Given this list of marker genes CEP128, AFF3, UPB1, SUFU, HSPA1B, LIG4, TPD52, TMED1, MAD2L1, GADD45B, ELOF1, LY6E, EIF4EBP1, DALRD3, TUBE1, MTMR14, PRCP, SPC24, DBNL, TFRC, MGAT1, FCHSD2, L1CAM, SH3GLB1, SLC66A1, TNS3, RAB39A, CFAP20DC, NCOA1, HLA-C, KDM2B, GALNT4, HTR4, PPP4R1, HDAC5, DAPP1, PIP4P1, ZBTB7A, BHLHE40, BCKDHA, ZNF326, HS6ST1 (heparan sulfate 6-O-sulfotransferase 1), OPN3, VPS11, SH3TC1, VHL, CWC25, HEMK1, ABCD1, SAPCD1, CNP, GDAP1L1, EBI3, RELB, WDFY2, PRIM2, FUS, GHDC, CIITA, PLBD1, DAZAP2, RAD51AP1, BRPF3, SMARCB1, RAB14, VIM (vimentin), PRDX4, SLC25A19, THBD, UQCRB, NUP210L, SMARCA5, CNTROB (NCBI Gene Id 116840), PPP5C, MED13, CYFIP1, EID1, NUP85, DCUN1D1, ALDH9A1, TMBIM4, RDH10, PPIH, SULF2, CDC27, NEDD9, SLC38A9, RAB24, GLUL, TMOD3, HNRNPH1, SLF2, DNAJC22, SERPINB7 (NCBI Gene Id 8710), POLR2J, EYA1, ZSCAN20, TXN2, BTBD9, SORD, ARID3B, PPP1R21, NDUFC2, NUP62, ANKRD37, RASGRP2, DYNLT2B, CXCR5, MAP1LC3A, CORO7, TOR1AIP1, SIX4, NFKBIE, ASNSD1, SDHAF2, RUFY1, ADAM9, ARHGAP25, RB1, BHLHA9 (NCBI Gene Id 730701), GADD45G, ANKFY1, SLC30A4, CLIC1, NXPE3, IL15, TPP1, STARD5, ATP2A3, UFM1, TEX30, TRAF3, PPHLN1, FEN1, PRXL2A, SKIL, HES1 (NCBI Gene Id 3280), OGFRL1, ATAT1, MON1B, RP2 (NCBI Gene Id 6102), SH3YL1, SP1, PFKFB3, CHML, SLC39A9, MYCBP, SLC4A7, ERCC6L, USP6NL, RPRD1A, ZFP91, SPATA46, IFT140, C9orf72, CNIH4, PIK3AP1, B4GALNT4, TACC3, POLR2K, GPX1, MACO1, ANKRD33B, EPS8, TRAPPC1, LENG9, EXOC6, DTX2, CD93, SNX13, RDH12, TYROBP, ZMYM4 (NCBI Gene Id 9202), MFAP1, BAP1, REEP5, CLIC4, LMBRD1, CDKN2C, PEX1, TSC2, BUB1B, CSF2RA, SON, ATP6V0B, HDAC10, BAZ2B, TIRAP, CARD11 (caspase recruitment domain family member 11), YEATS4, ATP6V0D1 (NCBI Gene Id 9114), PAIP2, BICD2, DHX38, PMF1, SCLY, TXNDC5, TK1, PBK, PSMA5, here is a description of the gene set: studied in species Homo sapiens Human Gene Set: GSE27786_BCELL_VS_CD8_TCELL_UP Each fraction of mouse hematopoietic cells was purified by cell sorting from bone marrow of 8-week-old C57BL/6 mice, and its gene expression was analyzed. from publication Konuma T, Nakamura S, Miyagi S, Negishi M, Chiba T, Oguro H, Yuan J, Mochizuki-Kashio M, Ichikawa H, Miyoshi H, Vidal M, Iwama A (PMID 21540074) Genes up-regulated in comparison of B cells versus CD8 T cells.